The following is a description of a gene set: Generalised myoclonic seizure provoked by flashing or flickering light. species: Homo sapiens Photosensitive myoclonic seizure Human Gene Set: HP_PHOTOSENSITIVE_MYOCLONIC_SEIZURE, and this is the list of marker genes: SCN1B, KCTD7, GABRG2, SCN9A, SCN2A (NCBI Gene Id 94312), PCDH19, GABRA1, SCN1A